The following is a description of a gene set: Genes having at least one occurrence of the motif GSGCGCGR in the regions spanning 4 kb centered on their transcription starting sites. This matches the ZFP161 transcription factor binding site V$ZF5_01 (v7.4 TRANSFAC). species: Homo sapiens Human Gene Set: ZF5_01, and this is the list of marker genes: SALL1, CACNA1A, SMTNL2, ELAVL3, SLC35C1, LAMP1, MAF, ZNRF1, KPNB1, HNRNPUL1, ARHGEF7, SCUBE2, TMEM132E-DT, SPRED1, UBALD2, HS6ST3, BNIP2, NR4A1, ASIC1, KCND3, UQCRH, SEZ6, ITPKA (inositol-trisphosphate 3-kinase A), VPS26B, CAP1, CDK2AP1, SENP3, TAL1, KCNH5, NSF, HPCA, UBTF, EIF4A1, WNT11, BCL7A, STMN1, MYCBP, HSD11B1L, SYT7, SMARCD1, SEMA7A, PIANP, C1orf21 (chromosome 1 open reading frame 21), CPSF7, PLXNC1, AJUBA, BMI1, TMEM132E, WNT1, ADO, NFATC4, APH1A, BTRC, FLI1, RNF10, TLE3, DCLK1, RRAGC, ZBTB8OS, XYLT2, FAM13C, HEXIM2, LZTS2, SHF, GRIN2B, KIF2C, IRX5, ASPHD1, ZNF362, RRP8, ST3GAL2, HIF1A, PHF23, TBX2, RHOG, NIN, MAP3K3, IGF2BP1, NR2F2, DDIT3, NUTF2, KDM2A, GFER, ZIC2, ITGA3, FOXD3, ELAVL1, APBB1, KCTD15, TMEM126B (NCBI Gene Id 95018), NCAPD3, CMPK1, ANKRD13A, NFATC1, PTBP1, ARHGEF12, DNM2, C17orf58, CORO1C, KIF1B, NTN1, NKX2-8, DLST, CELF4, FXR2, RNF19B, STARD13, SDHAF2, RAB31, GADD45B, EFNB2, SORCS3, HS2ST1, NGFR, RASGRF1, DRAP1, GRIK3 (NCBI Gene Id 2899), KCNC1, RASGEF1A, SLC25A33, LRRC41, TMOD2, TNPO2, LRFN5, KCTD12, EIF3A, RBBP4, GJB6, PRDM16, ADM, FUT8, TRIM8, PICALM, HIPK1, ZC3H10, BRSK2, MPZL1, CA10, PCGF5, PHOX2A, PRIMA1, POU3F1 (POU class 3 homeobox 1), TLX1, SELENOF, ARID4A, UBE4B, PAK1, KLC2, TPP2, PABPC4, ZDHHC5, MMP15, ABCC8, LIPT2-AS1, B4GALT2, PTGR3, SMPD3, SENP1, CTCF, STAT5B, PA2G4, SSBP4, HOMER3, ATP10A, RAB35 (NCBI Gene Id 11021), LBX1, KLF13, ST8SIA2, TGIF1, HS3ST3B1, DDAH1, MEX3B, SORL1, PHF12, MAX, ILK, UBE2N, TLK2, CCNE1, RPL41, FOSL1, POU4F1, TPM1, USP48, LRP8, PPIE, RNF125 (ring finger protein 125), RBM26, SPAG9, CRY1, HCN4, CDC42BPB, DSCAML1, MSI1, SEC14L1, LIMD2, FHIP1B (FHF complex subunit HOOK interacting protein 1B), AEBP2, FKBP2, TAOK2, JUNB, RAPGEFL1, SYT12, TM9SF3, NXPH4, GNB1, VPS26A, PPP1CC, SPTSSA, DDX23, ARHGAP44, MAZ, NEURL1, PPM1D, PCLAF (PCNA clamp associated factor), BICDL1, MICOS13, GPRC5C, RGS7, ZNF232, ALX4, ZBTB7A, LSM4, CALM1, PHC2, TRPM7, ZNF521, UTP18, SUMO2, C11orf68, YTHDF2 (YTH N6-methyladenosine RNA binding protein F2), ATP13A1, BCL7C, RLF, MLLT6, KIRREL3, FRAT1